The following is a description of a gene set: Binding to a molybdenum ion (Mo). species: Mus musculus Mouse Gene Set: GOMF_MOLYBDENUM_ION_BINDING, and this is the list of marker genes: Mtarc2, Mocos, Suox, Xdh, Aox3, Mtarc1, Aox4